The following is a description of a gene set: part of: Integration of energy metabolism Upon dissociation of protein kinase A (PKA) tetramers in the presence of cAMP, the released PKA catalytic monomers phosphorylate specific serine and threonine residues of several metabolic enzymes. These target enzymes include glycogen phosphorylase kinase, glycogen synthase and PF2K-Pase. PKA also phosphorylates ChREBP (Carbohydrate Response Element Binding Protein), preventing its movement into the nucleus and thus its function as a positive transcription factor for genes involved in glycolytic and lipogenic reactions. species: Homo sapiens Reactome Pathway: PKA-mediated phosphorylation of key metabolic factors, and this is the list of marker genes: PRKACA, PFKFB1, MLXIPL, PRKACG, PRKACB